Given this list of marker genes STAR, HSD11B2, STARD3NL, HSD3B2, SERPINA6, CYP19A1, CYP17A1, SRD5A2, HSD17B12, HSD17B14, STARD6, HSD17B1, FDX1, STARD3, HSD17B2, FDXR, SRD5A3, CYP11A1, TSPOAP1, TSPO, CYP11B2, AKR1B1 (NCBI Gene Id 231), STS, AKR1B15, FDX2, CYP11B1, HSD11B1, HSD17B3, STARD4, HSD3B1, SRD5A1, POMC, CGA, HSD17B11, CYP21A2, LHB, here is a description of the gene set: studied in species Homo sapiens Steroid hormones are synthesized primarily in the adrenal gland and gonads. They regulate energy metabolism and stress responses (glucocorticoids), salt balance (mineralocorticoids), and sexual development and function (androgens and estrogens). All steroids are synthesized from cholesterol. Steroid hormone synthesis is largely regulated at the initial steps of cholesterol mobilization and transport into the mitochondrial matrix for conversion to pregnenolone. In the body, the fate of pregnenolone is tissue-specific: in the zona fasciculata of the adrenal cortex it is converted to cortisol, in the zona glomerulosa to aldosterone, and in the gonads to testosterone and then to estrone and estradiol. These pathways are outlined in the figure below, which also details the sites on the cholesterol molecule that undergo modification in the course of these reactions. Reactome Pathway: Metabolism of steroid hormones part of: Metabolism of steroids